Given this list of marker genes GJA5, AP1S3, SMARCD3, CDH23, MMD, ERCC1, MCM9, ICAM4, COMMD5, XCR1, SPTSSB, ABCG5, BDH1, HOXA11-AS, AFG2B, FJX1, KPNA3, DNAJC6, CDK18, TMEM25, PLXNB2, SLC25A47, SGCB, TELO2, KIAA1191, HTR3A, PAX1, SYNE3, IFI30, GADD45B, PJA1, LGI2, FEN1, RORC, TMEM74B, GSTO2, CD248, TRIM28, BMPR1A, AGFG1, DOCK3, SCFD2, CYB5D2, SLC12A9, C1orf21, NETO2, TOP1MT, ATP2C2, PRPS2, FBXL15, NGEF, CEP170 (NCBI Gene Id 9859), TPGS2, MYCBPAP, ZDHHC23, HSPBAP1, HOMER2, BRI3BP, CD34, PABIR2, ST6GALNAC6, ENOPH1, IL2RA, GFUS, FOXF1, MYO1B, PEX12, LMX1A, TMEM41B, MMGT1, TUBA8, USP21, TLNRD1, VPS8, GPR151, HNRNPL, SLC35C2, C15orf39, S100A10, VTN, PTGDR, MLPH, CR1L, SNRPA1, DYNLL2 (dynein light chain LC8-type 2), FRZB, KLF17, IL11RA, UQCC2, ABCA5, MANF, XRCC6, FGD2, COX18, PRRT4, FTH1, UTS2R, SRP68, PSMA3, LPCAT4, AFP, PTTG1 (NCBI Gene Id 9232), STEAP4, BMP8B, SLC5A6, ALG11, OR10AD1, GUCA1B, KBTBD12, MUC20, MVP, FAM209A, PRR32, TSN, PRDX6, NANOS1, XPC, RBM14, NMT1, UEVLD, PCK1, HTR6, CMTM3, USP34, CCDC112, CRELD2, CRISP2, STARD7, PON3, AZIN2, KHDRBS3, VKORC1, PI4K2B, FAM83F, P4HA3, TMEM106B, TMEM181, AKR1B10, PTGFR, TRMT12, ARL5A (ADP ribosylation factor like GTPase 5A), NUTF2, RAB2A, MAVS, GAS2L1, RGS16, PHTF1, AZIN1, AHDC1, RNF214, PPP1R17, CEP55, SLC16A1, FABP9, ZFP30, NXPE3, RNPEPL1 (NCBI Gene Id 58159), LGALSL, CBX5, SLCO1A2, CABLES2, RTL8B, OPTC, TMOD4, TMEM44, CERS2, MGAM, POU3F1, SHQ1, ADORA2B, TAX1BP3, NABP2, PEMT, MTFR1L, C6orf141, IGSF8, TMEM200C (NCBI Gene Id 645369), CCDC187, TRAPPC1, CYP17A1, POLR2G, COPS7A, GPD1L, SEPTIN12, CDK2AP1, GPR20, RPL23A, DERL2, CDK1, UPK3A, GFRA4, NOPCHAP1, NAGPA, RANBP2, GRIA2, REG4, RPRML, RAB35, SECISBP2, SEMA7A, here is a description of the gene set: Genes up-regulated in lymphocytes treated with TNF for 2h: T conv versus T reg cells. Here we show that tumor necrosis factor (TNF) induced in human T-regulatory cells (Treg), as compared to conventional T cells (Tcon), a transcription program highly enriched for typical NF-κB target genes, such as: the cytokines LTA and TNF; the TNF-receptor super family members FAS, 4-1BB and OX-40; various anti-apoptotic genes; and other important immune-response genes. As an initial approach to examine the cellular program induced by TNF in Tregs versus Tcon cells, we employed microarray gene expression analysis at 2 and 24 hrs following TNF treatment. from publication Nagar M, Jacob-Hirsch J, Vernitsky H, Berkun Y, Ben-Horin S, Amariglio N, Bank I, Kloog Y, Rechavi G, Goldstein I (PMID 20181891) studied in species Homo sapiens Human Gene Set: GSE18893_TCONV_VS_TREG_2H_TNF_STIM_UP